Given this list of marker genes DBX1, GLI3, FOXN4, GLI2, LHX3, SOX1, DMRT3, DLL4, NKX2-2, SUFU, ASCL1, here is a description of the gene set: The commitment of cells to specific cell fates and their capacity to differentiate into particular kinds of cells within a field of cells that will exhibit a certain pattern of differentiation. Positional information is established through protein signals that emanate from a localized source within a developmental field resulting in specification of a cell type. Those signals are then interpreted in a cell-autonomous manner resulting in the determination of the cell type. studied in species Homo sapiens Human Gene Set: GOBP_CELL_FATE_COMMITMENT_INVOLVED_IN_PATTERN_SPECIFICATION